The following is a description of a gene set: species: Homo sapiens The portion of the plasma membrane surrounding an axon; it is a specialized trilaminar random mosaic of protein molecules floating within a fluid matrix of highly mobile phospholipid molecules, 7-8 nm in thickness. Human Gene Set: GOCC_AXOLEMMA, and this is the list of marker genes: KCNC2, ADORA1, ADORA2A, GABBR1, MAPT, SLC1A2, THY1, SPTBN1, MYO1D, CNTNAP2, EPB41L3, ROBO2, ANK1, KCNC1